The following is a description of a gene set: Mouse Gene Set: GOBP_UDP_METABOLIC_PROCESS The chemical reactions and pathways involving UDP, uridine (5'-)diphosphate. studied in species Mus musculus, and this is the list of marker genes: Dhodh, Cad, Entpd4, Entpd5, Entpd4b, Entpd7, Ak9, Cmpk1 (NCBI Gene Id 66588), Umps